Given this list of marker genes HLA-DRA, ISG20, DENND2D, CTSC, PARP12, GBP1, HLA-A, GIMAP5, CCL5, LYZ, CD38, SP110, UBE2L6, CTSB, HLA-DRB1, RAB20, HLA-DPA1, ARHGDIB, IFI27, LGALS3, C1QB, TRIM22, STAT1, CD83, GBP2, ADA2, PRC1, CD48, UCP2, TRBC1, CD5L, CD53, RGL1, FCER1G, IGSF6, ADGRE1, GZMA, HLA-B, C1orf54, PSME2, TPP1, HLA-F, PIK3CD, LAP3, TYMS, UBE2C, CXCL10, RRM2 (ribonucleotide reductase regulatory subunit M2), B2M, FGL2, HLA-DMA, APOL3, MCM6, TAPBP, GM2A, GPNMB, HLA-DPB1, COTL1, LAPTM5, IGHG1, PSME1, IFI30, KPNA2, WARS1, RAB27A, IGLC2, IL10RA, SOD2, TYROBP, GZMK, CD74, RFX5, FCGR1A, CXCR4, PSMB9, PBK, S100A10, IFI16, HLA-E, HLA-DMB, C3AR1, SLC7A7, PPT1, HLA-DQB1, THEMIS2, LPXN, RAC2, PLAC8, AURKA, SRGN, CFL1, PLAAT4, BTN3A3, TRGC1, RNASET2, PSMB10, CD3D, DRAM1, RAB31, PTTG1, VSIG4, CXCL9, GABBR1, here is a description of the gene set: species: Homo sapiens Genes induced in the liver during hepatitis B (HBV) viral clearance in chimpanzees. Human Gene Set: WIELAND_UP_BY_HBV_INFECTION Previous studies in hepatitis B virus (HBV)-infected humans and chimpanzees suggest that control of HBV infection involves the cells, effector functions, and molecular mediators of the immune response. The objective of the current study was to identify, in the liver of acutely HBV-infected chimpanzees, the spectrum of virus-induced and immune response-related genes that regulate the infection. The results demonstrate that HBV does not induce any genes during entry and expansion, suggesting it is a stealth virus early in the infection. In contrast, a large number of T cell-derived IFN-gamma-regulated genes are induced in the liver during viral clearance, reflecting the impact of an adaptive T cell response that inhibits viral replication and kills infected cells, thereby terminating the infection. from publication Wieland S, Thimme R, Purcell RH, Chisari FV (PMID 15100412)